The following is a description of a gene set: Mouse Gene Set: REACTOME_FGFR1B_LIGAND_BINDING_AND_ACTIVATION FGFR1b ligand binding and activation species: Mus musculus, and this is the list of marker genes: Fgf1, Tgfbr3, Fgfr1, Fgf22, Gipc1, Fgf10, Fgf2, Fgf3